Given this list of marker genes Ltbp3 (latent transforming growth factor beta binding protein 3), Bmpr2, Timp2, Smad2, Bmp10, E2f4 (NCBI Gene Id 72062), Cbl, Sp1, Amh, Ncor2, Acvr2a, Aph1b, Ccnt1, Ncstn, Fstl3, Tgfbr3, Ltbp1, Atp1b4, Fbn1, Rnf111, Ubc, Men1, Stub1, Fkbp1a, Amhr2, Itgb8, Inha, Parp1, Usp9x, Nog, Aph1a (aph1 homolog A, gamma secretase subunit), Bambi, Acvrl1, Itga8, E2f5, Psen1, Ccnc, Smad5, Acvr1c (activin A receptor, type IC), Furin, Gipc1, Tgif1, Arrb1, Itgav, Wwtr1, Pmepa1, Smurf2, Strap, Ube2d1, Arhgef18, Bmp2, Uba52rt, Ltbp4, Uba52, Tgfb1, Zfyve16, Ube2d3, Tgfbr2, Prkcz, Mmp16, Acvr2b, Ube2m, Smad1, Chrdl1, Fst, Rhoa, Ski, Tfdp1, Fgf2, F11r, Smurf1, Hdac1, Acvr1b, Tgif2, Fstl1, Rps27a (NCBI Gene Id 78294), Ltbp2 (latent transforming growth factor beta binding protein 2), Pard6a, Inhba, Smad7, Grem2, Rbl1, Itgb3, Smad6, Mapk3, Mmp14, Cgn, Tgfb2, Gdf2, Cer1, Itgb1, Nedd8, Ccnk, Mtmr4, Psenen, Ubb, Zfyve9, Itgb6, Skil, Cdk8, Inhbb, Tgfb3, Pard3, Arrb2, Tgfbr1, Smad4, Nedd4l, Smad3, Bmpr1a, Cdk9, Smad9, Ppm1a, Bmpr1b, Mapk1, Ccnt2, Timp1, here is a description of the gene set: studied in species Mus musculus Mouse Gene Set: REACTOME_SIGNALING_BY_TGFB_FAMILY_MEMBERS Signaling by TGFB family members